The following is a description of a gene set: Proteoglycan biosynthesis Human Gene Set: WP_PROTEOGLYCAN_BIOSYNTHESIS species: Homo sapiens, and this is the list of marker genes: B4GALT7, XYLT2, BPNT2, EXTL3, SLC26A2, XYLT1, B3GAT3, CHST14, CSGALNACT1, EXT2, SLC35B2, CHSY1, CANT1, SLC35B3, CHST3, B3GALT6, PAPSS2, EXT1